Given this list of marker genes Rnf7, Rbx1, Rbx1-ps, Rnf7l, Mdm2, here is a description of the gene set: Mouse Gene Set: GOMF_NEDD8_LIGASE_ACTIVITY species: Mus musculus Catalysis of the transfer of NEDD8 to a substrate protein via the reaction X-NEDD8 + S = X + S-NEDD8, where X is either an E2 or E3 enzyme, the X-NEDD8 linkage is a thioester bond, and the S-NEDD8 linkage is an isopeptide bond between the C-terminal amino acid of NEDD8 and the epsilon-amino group of lysine residues in the substrate.